Given this list of marker genes Setmar, Kmt2a, Mettl21c, Ash2l, Mettl21a, Dot1l, Kmt5c, Kmt2d, Prdm16, Mecom, Setd1a, Kmt5a, Prdm9, Smyd3, Setd5, Eef1akmt4, Nsd1, Nsd3, Setbp1, Prdm8, Kmt5b, Prmt5, Eef1akmt3, Smyd1, Ezh1, Setd7, Smyd2, Prmt8, Vcpkmt, Prmt1, Atpsckmt, Setd3, N6amt1, Eef1akmt2, Prmt2, Setd2, Ndufaf7, Camkmt, Ash1l, Eef2kmt, Suv39h2, Carm1, Setdb1, Nsd2, Suv39h1, Kmt2e, Eef1akmt1, Ezh2, Setd6, Ehmt2, Setdb2, Wdr5, Mettl13, Setd4, Smyd5, Prmt9, Etfbkmt, Setd1b, Kmt2b, Antkmt, Ehmt1, Kmt2c, Prmt6, Jarid2, Prdm6, here is a description of the gene set: Mouse Gene Set: GOMF_PROTEIN_LYSINE_N_METHYLTRANSFERASE_ACTIVITY species: Mus musculus Catalysis of the transfer of a methyl group from S-adenosyl-L-methionine to the epsilon-amino group of a lysine residue in a protein substrate.